Given this list of marker genes Nup62, Bicd2, Xpo1, Tnpo3, Nup153, Eif5a, Ranbp2, here is a description of the gene set: Mouse Gene Set: GOCC_ANNULATE_LAMELLAE Stacks of endoplasmic reticulum (ER) membranes containing a high density of nuclear pores, thought to form from excess nuclear membrane components, that have been described in a number of different cells. Annulate lamellar membranes are continuous with and embedded within the ER. studied in species Mus musculus